Given this list of marker genes FOXRED1, ATP6V1C2 (ATPase H+ transporting V1 subunit C2), HEATR1, SLC36A4, ARRDC5, TYW1, PDCD1LG2, PAK2, GPR135, EXOSC9, SLC32A1, RCC1, RBM15, MTCH2, TM7SF2, NME4, GPR19, CNOT9, PPIL3, PHKB, PPA1, PCDHA11, ALDOC, ZNF229, NEMF, NEK9, FILIP1L, WDSUB1, BTF3, CTPS1, NKX6-2, PSMA5, UXS1, PPIE, SDHB, FAM185A, FGF18, ICAM1, KDELR2, ERAP1, INTS2, EHD1, LAX1, ZC3H7B, TDO2, SEC22A, B3GAT1, DIO1, SDHAF1, PIM2, MAPKAPK3, PEPD, FGFR3, CCDC102A, ABHD5, SPATA3, TAT, EIF2AK4, HMGXB4, SMCO4, TRPM1, FAM162A, MRPL3, PUS1, FKBP9 (NCBI Gene Id 90212), BAZ1A, GUK1, HMBS, EID2, PTGER2, USP28, TSEN2, TMEM256, KYAT3, EMP3, MFSD2B, ENO3, PHYH, TTC27, ACTL6B, ECSCR (endothelial cell surface expressed chemotaxis and apoptosis regulator), EXOC5, RPL14 (NCBI Gene Id 9045), FGFBP3, CEP83-DT, ROPN1L, ATP5F1E, PSMA8, NOLC1, TIMM8A, PEAR1, RPL22, LIPT2, PDLIM4, PWP1, NCOA7, KPTN, CBR4, GZMA, TUBB3, TOMM40L, HELLS, SNRPA1, LONP1, ORAI3, SETD6, RPL6, SNRPF, B3GLCT, RCN1 (reticulocalbin 1), NDUFS1, NOD1, DAGLB, SKIC3, CLUAP1, SRGN, RIPK1, YBX1, RPS2, MBOAT1, RAB27B, TMTC4, EI24, ELP3, KAT2A, PSAT1, DPCD, BEND4, COX6C, KCTD9, C7orf50, MLH3, E2F6, PHKA1, THUMPD1 (NCBI Gene Id 55623, THUMP domain containing 1), TFB1M, ITIH5, ACP1, PAOX, MTHFD1, GPATCH1, RNF144A, RAB30, SKIC8, CCND2, TAF1D, IZUMO1R, ATAD3A (NCBI Gene Id 55210, ATPase family AAA domain containing 3A), ICOSLG, GCNT3, SALL3, EVA1C, FA2H, IFRD2, FAM216B, SLC38A1 (NCBI Gene Id 81539), RNF141, CLIP1, POU2AF1, TONSL (tonsoku like, DNA repair protein), IGHG1, OXCT1, RPF2, DDX21, IL2RB, DPY19L1, PSMA2, CCT8, CENPI, OPRK1, TSACC, CDH18, C1orf131, PRR11, CEP41, CHCHD10, IKZF3, PRKCH, RRBP1, ALK (NCBI Gene Id 238), PI16, TNFSF11, NCBP1, B4GALT5, FGA, GHRHR, RPL23, NHP2, CARD6, CADPS, RARS1, SWI5, SLC25A4, PLEKHA2, SMC6, SYTL4, DECR1, UAP1, MBOAT7, here is a description of the gene set: Genes down-regulated in comparison of CD4 CD8 thymocytes versus CD4 Int CD8 thymocytes. Human Gene Set: GSE13493_DP_VS_CD4INTCD8POS_THYMOCYTE_DN species: Homo sapiens T cell development relies on the precise developmental control of various cellular functions for appropriate positive and negative selection. Previously, gene expression profiling of peptide-driven negative selection events in the N15 TCR class I MHC-restricted mouse and D011.10 TCR class II MHC-restricted mouse has offered insights into the coordinate engagement of biological processes affecting thymocyte development. However, there has been little comparable detailed in vivo global genome expression analysis reported for positive selection. We used microarrays to identify the genes differentially expressed during CD8 single positive T cell development in N15 TCR transgenic Rag2 deficient mice. from publication Choi YI, Duke-Cohan JS, Ahmed WB, Handley MA, Mann F, Epstein JA, Clayton LK, Reinherz EL (PMID 19027330)